Given this list of marker genes Aste1, Col9a3, Echs1, Eif5a, Magi2, Ube2i, Rhbdl2, Gm23390, Gm15780, Ezh1, Gripap1, Itgbl1, Hdac4, Fcna (NCBI Gene Id 14133), Btbd19, Wdr81, R3hdm2, Lrfn5 (leucine rich repeat and fibronectin type III domain containing 5), Scn1a, Slc1a2, Metap2, Mir411, Dlat, Gstt3, Usp21, Mir7035, Shbg, Plekha3, 4930568G15Rik, Ddx23, Smpd5, Stt3b, Nudt1, Pdpk1, Spock2, Gltpd2, Defb38, Nbeal2, Gm6736, Zbtb20, Slc38a6, Gm10649, Gm13110, Timm17b, Lancl1, Ninj2, Gm29994, Sec16a, Efna3, Ikbke, St6galnac2, Gm4911, Tcea2, 4930517L18Rik, Mir1199, Gm25137, Gpr62, En1, Ctsh, Pwwp3a, Crispld2, Gm15328, Cep63, Cage1, Plekha6, Tpm3, Psmd11, Cep164, Bin2, Bex6, Eno4, Rcbtb1, Atp6v0a1, Cltc, Plekha5, Mir7010, Nrde2 (NCBI Gene Id 432687), Tnks2 (tankyrase, TRF1-interacting ankyrin-related ADP-ribose polymerase 2), Elk4, Mir568, Tomm34, Mepce, Ift81, Eri3, Gm28900, Cd164, Postn, Gm13785, Tpd52l2, Gtf2h2 (general transcription factor II H, polypeptide 2), Nbdy, Mgst3, Taf1c, Elavl4, Gm10059 (NCBI Gene Id 100503585), Usp19, Or1p1c, Gtdc1, Ehbp1, Arih2, Kmt5c, Lag3, Tango2, Lap3, Sipa1l3, Amz1, Tagln2, 4930593C16Rik, 2900092N22Rik, Gm23116, Csnk1g3, Il2ra, Cwh43, Top3b, Celf1, Gm15779, Kcnh8, Misp3 (MISP family member 3), Tank, Ppp2r5c, Thap6, Nme4, Atp8b2 (NCBI Gene Id 54667), Lamp2, Uckl1, Gm29718, Pik3r4, Triap1, Arhgap20, Pus1, H2bw2, Mylpf, Srsf9, Hexim2, Zfp957, Atf7ip, Lhfpl4, Gpr107, Chd2, Cpt1c, Pramel7, Dhx33, Mybpc1, Sidt2, Cct3, Gm14010, Gm12924, Sox15, Gm8398, Nlrc3 (NCBI Gene Id 268857), Fam169b, Gm12650, Itpa, Tgfbr2, Atp5mj, Trcg1, Lcor, Mrpl18, 1700008O03Rik (RIKEN cDNA 1700008O03 gene), Nfasc, Gm12654, Map1lc3b, Gm14210, Ctsa, Cuedc1, Gm27811, Fam193b, 4933434E20Rik, Otud4, Naa16, H1f11-ps, Kcnv2, Elapor1, Myo5b, Pif1, Spag5, Pcmtd2, Togaram2, Kbtbd4, Chd7, Rnaseh2a, Slc36a3os, Tulp3, Recql, Stox2, Gpkow, Larp4, Gm6733, Pgap1, Med23, Mfsd2b, Ncor1, Faim2, Gm16096, Banp, Zfp866, Lat2, Sbno1, Rcan2, Spin1, Usp51, Dhx30, 1700036A12Rik, Islr, Ncam2, Uqcrc2, Cd300e, Gm14491, Smtn, Pla2g10, Mir654, Gcc1, Grm1, Zfp280d, Zfp574, Slc25a19, Tnik, Uba5, Gm7097, Tmem42, Gm23347, 4933406P04Rik, Gata4, Sema4d, Prrc2a, Rpl38, Gadd45b, Gm11771, Rrp7a, Hoxa3, Mir124a-1hg, Garnl3, Ddb2, Platr22 (pluripotency associated transcript 22), Nktr, Cdkn1a, Gm12571, Kdm5a, Flt1, Xrn1, Cirbp, Myo10, Hspa8, 1700025G04Rik, Cdh13 (NCBI Gene Id 74373), Selplg, Heg1, Xpnpep1, Zfp143, Anxa7, Slc2a3, Cnppd1, Trap1, Ctnna3, Zhx2, 1810053B23Rik, Ccdc198, Rtp3, Arrdc3, Or1a7-ps1, Zfp7, Wfs1, Gm3830, Wrap53, Rdm1, Surf6, 4930532M18Rik, Krtap20-2, Zdhhc15 (zinc finger, DHHC domain containing 15), Capns1, Rps12-ps7, Ercc2, Cngb3, Sf3a3, Gm4915, Vhl, Usp49 (NCBI Gene Id 224836), H3c11, Klhl22, Ly6g6f, Tet2, AU016765, Gm24400, Vwf, Gm12236, Tmco2, Tmem53, Mix23, Mir1306, Ep400, Fam131a, Zmynd12, Il15ra, Sapcd2, Gm11665, Tgoln1, Lyl1, Uba7, Adam1a, Arhgap18, Hspa4, Tsc22d4, Gm7094, Mrpl30, Sptan1, Hhip, Gm5258, Habp2, Pde8a, Gm6985 (predicted pseudogene 6985), Cd180, Uhrf1, Mrpl22, Faddos, Alas1, Atp2c1, Pnpla7, Pwp2 (PWP2 periodic tryptophan protein homolog (yeast)), Ctbp2, Ergic1, Plgrkt, Park7, Gm11292, Or6c8, Nrl, Gm8186, Rad51ap2, Mir376a, Gm19637, Slc7a2, Nr3c2, Nell1, Rragc, Zfat, Vav1, Opcml, Gatad2a, 4930528J11Rik, Ighg1, Shmt1, Ppfibp2 (PTPRF interacting protein, binding protein 2 (liprin beta 2)), Fbxl22, Ndufa12-ps, Mir376b, Nfe2, Trip12, Gm12313, Elane, C030013C21Rik (NCBI Gene Id 77417), Phlpp2, Trp53cor1, Lbhd1, Ablim1 (NCBI Gene Id 72478), Pan3, Abcb9, Inpp5k, Elp1, Acot11, Rab30, Dmxl2, Ppil2, Gm26176, Baz1b, Gpr84, Dnajc17, Dnajc11, P2rx3, Tigd4, Rell1, Lima1, Taf4, Mir6365, A930007I19Rik, Fbxo21, Gm25788, Fam83c, Zfr, Zfp747l1, Zfp318, Slc25a53, Atp8b4, Phex (phosphate regulating endopeptidase homolog, X-linked), 4930512H18Rik, Or55b4, Defb40, Diaph1, Slc25a38, Man2c1, Rps6kb1, Psma3, Myg1, Milr1, Gm28836, Crisp4, 0610040F04Rik, Tpk1, Cd209d, Zdhhc4 (zinc finger, DHHC domain containing 4, NCBI Gene Id 72881), Gm12189, Gm9599, Mfge8, Map4, Sema4g, Zfp512b, Itgal, Gm12464, Car11, 9330162B11Rik, Catsper2, Ttf2, Mirg, Fuca1, Shf, A430072P03Rik, Anp32e, Gm23527, Otx2os1, Tent4b, Gm10268, Kcnj16, Mir103-2, Vgll4, Agps, Prss40, Lcp1 (lymphocyte cytosolic protein 1), Gm25862, Birc6, Pds5a, Gm11444, Gm6602, Cygb, Ift122, Dll1, Ppfia1, Kcnt2, Fanca, Epha10, Gm12620, Sass6, Cib1, Dnmt3l, Gm25369, Cd9, Fam83e, Itpr2, Nol11, Tifab, Gm29485, Spink10, Zfp101, Mir6385, 9430007M09Rik, Gna11, Gm15610, 1700019D03Rik, 2510002D24Rik (NCBI Gene Id 72307), Ankrd61, Dpep3, Acad11, Kdm1a, Nos1, Adam32, Atosb, Ube2h, Rsu1, Sulf1, Cfp, Prc1, Pou6f1, Zfp428, G3bp2, Rbm6, Cers6 (ceramide synthase 6), Pik3ap1, Fam53b, Mrpl21, Erg, Atp6v1e2, Taldo1, Sspn, Eef1e1, Fbrsl1, Lingo4, Slc38a8, Pi4kb (phosphatidylinositol 4-kinase beta), 1700088E04Rik, Fcgr3, Sp2, Bmt2, Riok1, Stk32b, Taf13, Hs3st3a1, Zfp106, Kif5b, Setd1a (SET domain containing 1A), Mms19, Ehd4, Mrm2, Utp14a, Entrep3, Kptn, Mir7069, Hlx, Tanc2, Pop1, Ccdc163, Bmal1, Fxr2, Calcoco2 (calcium binding and coiled-coil domain 2), 1110002J07Rik, Pdzd2, Mir7057, Luc7l3, Maf, Wfikkn1, Tfap4, Prcc, Gm25184, Acyp1, Sec31a, Phrf1, Ess2, Dhx29, Itih3, Kntc1, Kif2c, Dtnb, Irf3, Lpcat1, Ggt7, Defb22, Lrrc23, Hmgb1, Smco4, Timm17a, Zfp282, Mtmr3, Zfp961, Pdpr, Phactr1, Gm23090, Jak1, Defb44-ps, Tdrd9, 4930505A04Rik, Ubap2, Cip2a, Cenpi, Bltp3a, Mecr, Gm11197, Smok3b, Platr27, Sox4, Nmnat3, Slc25a36, Taok2, Bnc1, Dbpht2, P2rx7, Akr7a5, Gm14175, Uba52, Pbrm1, Nsun5, Zfp202, Cdc42ep1, Nsun4 (NOL1/NOP2/Sun domain family, member 4), Smg7, Gm13529, Frmd5, Tubgcp3, Ubr7, Mrps11, Cav1, Slc36a1, Npdc1 (neural proliferation, differentiation and control 1), Mbd5, Dohh, Clec2d, Pde4d, Gin1, Atg2a, Gm22935, Hvcn1, Lrrc42, Gm17076, Rtn4, Recql5, Oplah, Ficd, Crybg2, Gm24296, Tbc1d9b, Gm12101, Cdx1, Sin3b (NCBI Gene Id 69949), Dlgap5, Kash5, Gm26049, Gnas, Mcf2l, Gm14856, Slain1, Adamts6, Src, Crppa (CDP-L-ribitol pyrophosphorylase A), Gcnt7, Psmb3 (NCBI Gene Id 99155), Gm26684, C230071H17Rik, Onecut3, Ckap2, Krtap20-22, Gm4914, Gm10309, Zic1, Gm25482, C130036L24Rik, Il17rc, Gm25526, Eif2d, Pdcd6ip, Bcas1 (NCBI Gene Id 99084), 9530082P21Rik, Znfx1, Zfp142, Slco1c1 (NCBI Gene Id 58807), Mir152, Klhl12 (kelch-like 12), Trim6, Ccdc47, Vpreb1a, H2-M5, Pacrg, Ly96, Mir7060, AI661453, Slc1a3, Plaa, Crem, Adamts1, Spp1, Zfp395, Adat1, Rcor3, Gtf3c2, Rab11a (RAB11A, member RAS oncogene family), Nek2, Dync1h1, Sh3kbp1, Zp1, Psma4, Snord52, Kcnab2, Gm15413, Oaz2-ps, Fh1, Gm18254, Psma7, Tkt, C2cd5, Hspa9, Srrm1, Pou2f2 (NCBI Gene Id 18987), Tatdn2, Ing4, Sez6, Zfp661, Rpl21-ps9 (NCBI Gene Id 674852), Wdr47 (NCBI Gene Id 99512), Pdk1, Pi4ka, Nicn1, Mpzl2, Snora2b, Serpine2, Dlk1, Ldha, Fkbp10, 9430015G10Rik, Atrip, Bcas3, Tex2, A330102I10Rik (NCBI Gene Id 77920), Matn3, Snf8, Mir770, 4930556N13Rik, Mir142, B3gat1, Ccdc185, Gm8550, Cngb1, Srpk1, Ppp4r1, Ccdc9, Pitpnm2, Ascc1, Ttf1, Gm16342, Ptrh2, Gm23706, Ephb6, Wdr75, Gm22270, Tfrc, Slc25a35, Gadd45g, Faiml, Setdb2, Ttc39c, Mtif3, Mdn1, Strada, Kdm5c, Lmo7, Spcs1, Gm30292, Gm12980, Mlkl, Fcgr2b, Clcn7, Phf20, Tmem140, Mbtps2, 5830487J09Rik, Pramel13 (NCBI Gene Id 97182), Fam98c, Tent2 (NCBI Gene Id 218445), Abcc3, E2f1, Gpr35, Lmo3, Gm26081 (NCBI Gene Id 115486204), Dnajb2, Dnaaf9, Mroh1, Ggnbp2 (NCBI Gene Id 97681), Dhps, Cpa2, Arhgap26, Golga5, Mis18a, Cp, A830035A12Rik, Atcay, Stx18, BC050972, Mir3475, Ppard, Smpd1 (NCBI Gene Id 20597), Sergef, Gm7831, Plin1, Prss43, Upk3b, Cln3, Bclaf3, Sqstm1, Bola3, Gm17806, Tmem200a, Psma1, Usp33, Aff1, Gm26795, Matk, Sp1, Tmem47, Kat14, Ksr1, 2810407A14Rik, Cars2, Pnpla3, Traj58, Evl, Gm15266, 4930533L02Rik, Atf6, Gm19705, Gm4847, Rnf4, Gnai2 (NCBI Gene Id 97505), Fam219aos, Gm11637, Myh14, Bckdhb, Slc8a1, Gm11198, Gm10062, Pcsk6, Gm16351, Hsd3b7, 2310034O05Rik, Ipo13, Gm34248, 4933408N05Rik, Fam76a, Ruvbl1, Gm23382, Bola2, Gm24068, Tamm41, Gm23325, Mdk, Cemip, Ints13, Gm11619, Tmem242, Zfp354c (NCBI Gene Id 319696), Plin2, Meioc, 1500015A07Rik, Rps6-ps3, Acaa1b, Bcl7b, Msh3, Pole2, Nrbp1, Gm12333, Enah, Simc1, Gm43772, Gm42799, Abhd5, Gm7181, Gpi1, Cep85, Atp6v0a2, Slc2a9, Tnfrsf1a, Gm11349, Ica1l, Gse1, Lmf1, Nr1h4, Zfp612, Gm23123, Cyp4a28-ps, Nostrin, Palld, S100a4, Slx4, 1700020L13Rik, Gm30648, Ets1, Dsc1, Mfap1b, Ssc4d, Dse, Gm7299, Gm22972, Ccndbp1, Gm17966, Eif2ak4 (NCBI Gene Id 27103), Mkks, Aebp2, Gm22881, Slc35a4 (solute carrier family 35, member A4), Gm22122, Hmg20b, Gm16185, Plcxd2, Nup160, Idh3b, Eya3, Klf13, Gm2474, Gm26070, Taar9, Drg1, Lactb2, Trpm1, Sipa1, Thpo, Slit3, Gm9506, Gm24145, Rnf115, Uggt1, Phf24, Gm15651, Nipbl, Mir3085, Gm8190, Sumf2, Rab3gap1, Tgif1 (TGFB-induced factor homeobox 1), 1110038B12Rik, Gm12125, Foxl2os, Hes1, Erbb4, Otx2, Esrp1, Gm12608, Nvl, Smg5, Plekhg1, Uts2r, Atp8b3, Shc1, Borcs5, Nudt7, Tpr, Amz2, Clstn1, Gtf2a1, C5ar1, Ogt, 6030468B19Rik, Caskin2, Rab27a, Gm15222, Icos, Babam2, Msmo1, Nhsl2, Scrn2, Sun1, Gm27219, Aifm3, Zdhhc5, Wdr95, Elavl2, Adipor2, Cox7b, Spry4, Or2r2, Pick1, Zbtb8a, Gm14987, Tonsl, Pax2 (paired box 2), Gm20706, Tmem231, Hsp90ab1, Abo, Casp8 (NCBI Gene Id 12370), Cpsf4, Mir3618, Rack1, Ccr4, Txndc9, Cxxc1, Rabl6, Hoxa11, Hapln1, Ywhag, Supt7l (SPT7-like, STAGA complex gamma subunit), Igf1, Prickle4, Capza1, Mllt11, Babam1, Arpc5l, Gpr45, Afap1, Mcfd2, Mcm3ap, Ttc24, Usp10, Gm12936, Wars1, Ephx3, Pnliprp1, Il23a, Jakmip1, Gm22422, Ccdc65, Cldn22, Hint1, Gm22497 (predicted gene, 22497), Gm6491, Mrpl28, Ltbp1 (latent transforming growth factor beta binding protein 1), Appl2, Hoxa7, Slc36a4, Exosc2, LTO1 (NCBI Gene Id 72284), Zhx3, A630072M18Rik, Ak4, Gm12610, Oaz3, Rnf157 (NCBI Gene Id 69919), Acy1, Bcl2l1, Igfbp4, Neurl4, Gm10531, Or5p52 (NCBI Gene Id 258770), Stk31, Mir6372, Tnfsf15, Gm18859 (NCBI Gene Id 100417838), H2-K1, Prkacb, Gm12339, Arfgef1, Mir6417, Zfp748, Fkbp7, Cbr4, Vps8, Pde9a, Lrrc9, Atg14, Grsf1, Gm24978, Arhgap45, St14 (NCBI Gene Id 19143), Slx4ip, Tma7, Mxd3, Gamt, Hectd2os, Hormad2, Pakap, Mcph1, Fmc1, Camk2d, Entpd1, Gm9496, Fat2, Ankrd44, Pole, Ccdc141, Mis18bp1, Arhgef7, Btnl10, Gnl3l, Gm13690, Mir337, Kcnip4, Ccdc14, Gnb1l (NCBI Gene Id 64504), Shroom3, Jkamp, Cldn12, Gm12091, Nsa2, Foxm1, Mvd, Gm16089, Txnrd2, Gm15901, Ncmap, Hcls1, Tmem202, Txnrd1, Rere, Lims1, Il4, Srpk2, Gm14125, Bloodlinc, Nova1 (NCBI Gene Id 664883), Sardh (sarcosine dehydrogenase), Snx4, Misp, Mlxip, Ndfip2, Ccdc28a, Pigh (NCBI Gene Id 77819), Arhgdib, Uba1, Ly6g, Cfap251, Olig3, Reps1, Lbr, Gm23508, Eif1ad, Azin2, Tnc, Pik3r1, Rffl, Glra2, Mir5128, Mthfsd, Ralbp1, Psph, Tbx3, Klf1, Kdm4d, Gon4l, Cfap74, Tcf7l2, Cbfb, Gpc2, Hnrnpr, Ctdspl2, Ppp4r4, Ern2, Pcbp3, Rbms3, Dpp4, Rtel1, Rfx2, Ptp4a1, Fam193a, Gm16016, Kcnk6, Arf4, Tspan17, 4930447F24Rik, Knl1, Cwc15, Stat5a, Slc30a2, Awat2, Tulp1, Tsg101, AY702102, Lztr1, Thrap3, Dgcr8, Sag, Gm5251, Agfg2, Ptch2, Wnk1, Tbx3os1, Echdc2, Tsen54, Rtl5, Cntnap5c, Samsn1, Ptges3, Tsga13, Nedd4, Smok3a, Mir7013, Gfi1, Treml4, Slu7, Dst, Smg6, Med1, Rab43 (NCBI Gene Id 70089), Chchd2-ps, Gm12687, Gm12740, Gnpat, Mir99ahg, Gm12828, Olfr1401-ps1, Traj1, Ermp1, Pgap2, Tnfrsf26 (NCBI Gene Id 244237), Tef, Pglyrp3, Ankrd40, Stag3, Slc7a11, Msrb3, Scn9a, Gm6096, Tm4sf5, Slc35a3, Ncaph, Gm8213, Csf1r, Tspan12, Exosc1, Ntpcr, Tjp1, Mto1, Rpl30-ps5, 2210417A02Rik, Utp25, Glis3, 5730480H06Rik, Gm23341, Naa35, D830025C05Rik, Or2c1, Parp11, Mzf1, Gm8849, Gm5532, Lrrc37, C230066G23Rik, Amigo1, Phox2b, Snta1, Eva1b, Gm5764, Oas2, Gm25609, 4932412D23Rik, Kit, Prrt1b, Gm15032, Mgst2, Dbn1, Atp5f1b, Celf3, Mast1, Bdh2, Gtf2ird1, Rpl27, Rfx7, Rnf169, Gm37885, Bnip1, Med18, Ect2, Gm10532, Ushbp1, Hnrnpf, a, Mb, Arhgap28, Gm9078 (predicted gene 9078), Rfc4, Mir370, Ndufa10, Lrriq1, Nbr1, Pcdh19, Gsdma2, Sos1, Zfp36l1, Mir6997, Dhx32, Slc35d1, Hkdc1, Pomgnt1, Tekt5, Strap, Srebf1, Arpp21, Eeig1, Fkbp8, Farsa, Lrrc75aos1, Gm16225, Copz2, Thoc2l, Plekhs1, Alg11, Myo1c, Csdc2, Morrbid, Gm28874, Dsn1, Ptpn4, Tcp1, Cacnb4, Gm24461, Rad54l, Tmem131l, 2900079G21Rik, 4933440N22Rik, Hoxa11os, Neil1, Orc2, Zbtb34, Tcirg1, Gm26207, Gm5473, Ndufs4, Cul3, 6430548M08Rik, Sirt7, Tfdp1, Gm15197, Sgip1, Gm15550, Foxd2, 1700109H08Rik, Mir3965, Hhat, Defb23, Tpd52, Ubald1, Ddx19a, Atxn1l, Kank3, Tjp2, Slc12a6, Agap3, B4galnt3, Fyn, Ift172, Atg13, Or6n1, Taf6l, Rbm41, Tns3, Ubxn4, Kctd3, Dnmt3a, Bcar3, Mir129-2 (NCBI Gene Id 723953), Snx1, Nectin3, Peg10, 1700029H14Rik (RIKEN cDNA 1700029H14 gene), Aida, Rufy2, Bnip3l, Nmnat2, Pabpc4, Slc43a1, Tspyl2, Slc1a1, Vps72, Pgam1, Flad1 (NCBI Gene Id 319945), Virma, Gm24888, Mir6944, Kcnk2, Gm9887, Rpn2, Sdf2, Taf1d, Znrf1, Lrriq4, Ralgps1, Gak (NCBI Gene Id 231580), Ncoa4, Sntb2, Gm12109, Pdzk1ip1, Pask, Togaram1, Wdfy3, Plcb2, Degs2 (delta 4-desaturase, sphingolipid 2), Gm18407, Slc29a2, Gm19261, Fam117a, Cenpo, 1700039M15Rik, Rhot1, Lrsam1, Cep95, Ufsp2, Gm11517, Ltbp3 (latent transforming growth factor beta binding protein 3), Trim67, Skida1, Nr3c1, Anapc15, Abcb8, 1700129L04Rik, Mir7046, Eva1c, Dock10, Chn1, Vamp1, Ext1, Pdlim5, Cdr2l, Runx3, 1700052H01Rik, here is a description of the gene set: from publication Yevshin I, Sharipov R, Kolmykov S, Kondrakhin Y, Kolpakov F (PMID 30445619) Mouse Gene Set: ZFP92_TARGET_GENES studied in species Mus musculus Genes containing one or more binding sites for (Zfp92) in their promoter regions (TSS -1000,+100 bp) as identified by GTRD version 20.06 ChIP-seq harmonization.